Given this list of marker genes POLR1A, TCOF1, TWIST1, SLC25A24, FRAS1, CDH11, FREM1, ALX1, SF3B2, here is a description of the gene set: A short discontinuity of the margin of the upper eyelid. Human Gene Set: HP_UPPER_EYELID_COLOBOMA species: Homo sapiens Upper eyelid coloboma